Given this list of marker genes Psmb11, Psmb6, Psmb7, Psmb4, Psmb3, Psmb9, Psmb1, Psmb2, Psmb8, Psmb10, Psmb5, here is a description of the gene set: The proteasome core subcomplex that constitutes the two inner rings of the proteasome core complex. An example of this component is found in Mus musculus. Mouse Gene Set: GOCC_PROTEASOME_CORE_COMPLEX_BETA_SUBUNIT_COMPLEX studied in species Mus musculus